The following is a description of a gene set: species: Homo sapiens Human Gene Set: WP_GLYCOSAMINOGLYCAN_SYNTHESIS_IN_FIBROBLASTS Glycosaminoglycan synthesis in fibroblasts, and this is the list of marker genes: HS2ST1, CHST3, B3GALT6, EXTL2, CSGALNACT2, DSE, EXTL1, HS3ST3B1, CHST14, CHST11, CHST12, NDST3, CHPF2, EXTL3, CHST1, HS6ST3 (NCBI Gene Id 283476), CHPF, EXT1, GLCE, HS3ST1, CHST13, CHSY1, EXT2, B3GAT2, UST, CHSY3, B3GAT1, HS3ST2, CHST7, XYLT2, CHST15, NDST2, HS6ST1, HS6ST2, XYLT1, NDST4, B4GALT7, HS3ST3A1, CSGALNACT1, NDST1, B3GAT3